Given this list of marker genes Pak4, Zscan18, Spink1, Psd4, Scmh1, Tnfsf11, Pgap6, Rabl3, Hsd11b2, Wnt4, Tspan13, Foxa1, Hmgcs2, Pxylp1, Tbx3, Drc3, Lmntd2, Zdhhc1, Edem1, Mboat1, Dnajc12, Gale (NCBI Gene Id 74246), Fgl1, Sult2b1, Rasef, Slc7a4, Flvcr2, Tmco3, Cacnb3, Meis1, Cacng4, 2610528J11Rik, Yipf6, Hdac11, Slc22a18 (solute carrier family 22 (organic cation transporter), member 18), Pgr, Nsd3, Tgm2, Vopp1, Arfgef3, Lnx2, Sprr1a, Eps8l1, Zfhx2, Eef1a2, Pon3, Slc40a1, Abca7, Spdef, Tspan1, G6pdx (glucose-6-phosphate dehydrogenase X-linked), Sort1, Fyco1, Phka1, Pvalb, Dusp10 (NCBI Gene Id 98270), Slc7a2, H4c12 (H4 clustered histone 12), Gadd45g, Fer1l4, Lama5, Slc44a4, Batf, Wnt5a, Acot11, Wnk4, Reep6 (receptor accessory protein 6), Gmpr, Bbof1, Gprc5c, Faah, Btrc, Hoxb2, Ankmy2, Tox3, Tango2, Klhl5, Mindy1, Plekhg3, Aldh3b2, Fgf13, H4c11, Slc16a5, Ptpn6, Hes6, Myb (NCBI Gene Id 97674), Abcc8, Casz1, Hid1 (NCBI Gene Id 217310), Vps33b, Alcam, Trim6, Kbtbd4, Trp53inp2, Ccdc92, Prlr, Sgms1, Il13ra1, Atp6v0e2, Aldh3b1, Esr1, Wnt7b, Prom2, Aqp11, Cited1, Meis3 (Meis homeobox 3), Nectin4, Ern1, Tmprss6, Fbxo36, Dnaaf3, Tubg1, Mlph, here is a description of the gene set: from publication Lim E, Wu D, Pal B, Bouras T, Asselin-Labat ML, Vaillant F, Yagita H, Lindeman GJ, Smyth GK, Visvader JE (PMID 20346151) Genes consistently up-regulated in mature mammary luminal cells both in mouse and human species. species: Mus musculus Mouse Gene Set: LIM_MAMMARY_LUMINAL_MATURE_UP INTRODUCTION: Molecular characterization of the normal epithelial cell types that reside in the mammary gland is an important step toward understanding pathways that regulate self-renewal, lineage commitment, and differentiation along the hierarchy. Here we determined the gene expression signatures of four distinct subpopulations isolated from the mouse mammary gland. The epithelial cell signatures were used to interrogate mouse models of mammary tumorigenesis and to compare with their normal human counterpart subsets to identify conserved genes and networks.METHODS: RNA was prepared from freshly sorted mouse mammary cell subpopulations (mammary stem cell (MaSC)-enriched, committed luminal progenitor, mature luminal and stromal cell) and used for gene expression profiling analysis on the Illumina platform. Gene signatures were derived and compared with those previously reported for the analogous normal human mammary cell subpopulations. The mouse and human epithelial subset signatures were then subjected to Ingenuity Pathway Analysis (IPA) to identify conserved pathways.RESULTS: The four mouse mammary cell subpopulations exhibited distinct gene signatures. Comparison of these signatures with the molecular profiles of different mouse models of mammary tumorigenesis revealed that tumors arising in MMTV-Wnt-1 and p53-/- mice were enriched for MaSC-subset genes, whereas the gene profiles of MMTV-Neu and MMTV-PyMT tumors were most concordant with the luminal progenitor cell signature. Comparison of the mouse mammary epithelial cell signatures with their human counterparts revealed substantial conservation of genes, whereas IPA highlighted a number of conserved pathways in the three epithelial subsets.CONCLUSIONS: The conservation of genes and pathways across species further validates the use of the mouse as a model to study mammary gland development and highlights pathways that are likely to govern cell-fate decisions and differentiation. It is noteworthy that many of the conserved genes in the MaSC population have been considered as epithelial-mesenchymal transition (EMT) signature genes. Therefore, the expression of these genes in tumor cells may reflect basal epithelial cell characteristics and not necessarily cells that have undergone an EMT. Comparative analyses of normal mouse epithelial subsets with murine tumor models have implicated distinct cell types in contributing to tumorigenesis in the different models.